The following is a description of a gene set: Human Gene Set: HP_ABNORMAL_TOTAL_B_CELL_COUNT studied in species Homo sapiens Abnormal total B cell count The absolute number of B cells in the blood, per microliter is above or below the upper limits of normal of the reference range for the appropriate sex and age-group., and this is the list of marker genes: FASLG (NCBI Gene Id 356), TNFRSF9, CARD11, RAC2, IKZF3, UNC119, WDR1, RAG1, FAS, NCKAP1L, MYD88, SPI1, IL2RA, PIK3CD, LYN, TCF3, RAG2, PRIM1, IVNS1ABP, ALG12, FNIP1, GATA2, PTPRC, CASP10, IKBKG, PSMB10, DCLRE1B, PRKCD, BTK, ARHGEF1, RIPK1, FCHO1, TLR8, STAT1, SASH3 (NCBI Gene Id 93952), MAP3K14, NBN, LRBA, IKZF1, ZBTB24, PRKDC, POLD1, TRNT1, RFX5, MCM10, ATP11A, DOCK8, GFI1, PTEN, NFKB2, ADA, SLC39A7, B2M (beta-2-microglobulin), PIK3R1, KNSTRN, NHEJ1, REL, IGHM, IGLL1, CD79A, ICOS, JAK3, DCLRE1C, CD79B, MYSM1, POMP, SYK, NFKBIA